Given this list of marker genes AMN, GRM7, CUBN, LMBRD1, HLA-DQA1, CBLIF, GUCY2C, HLA-DQB1, ABCD1, SLC19A1, here is a description of the gene set: Human Gene Set: HP_DECREASED_CIRCULATING_VITAMIN_B12_CONCENTRATION Decreased circulating vitamin B12 concentration studied in species Homo sapiens The concentration of vitamin B12 in the blood circulation is below the lower limit of normal.